Given this list of marker genes Gpha2, Reg3g, Sst (somatostatin), Prl3c1, Prl3d3, Gh, Retnlb, Prl8a1, Prl3d1, Kng2, Retnla, Nts, Fndc5, Iapp, Ostn, Nppa, Qrfp, Agrp, Sct (NCBI Gene Id 20287), Crhr2, Cga, Pdyn, Prl4a1, Pomc, Ecrg4, Ucn2, Inhbb, Metrn, Cort, Prl7a1, Lep, Crh, Bglap2, Nmb, Copa, Metrnl, Hamp2, Gfral, Gcg, Insl5, Adipoq, Rln3, Reg3b, Reg3a, Prl2b1, Cck, Prl2a1, Pthlh, Ucn, Galp, Avp, Vgf, Rln1, Adcyap1, Calcb, Prl5a1 (NCBI Gene Id 74232), Prl3d2, Prl6a1, Gnrh1, Enho, Edn2, Insl3 (insulin-like 3), Angptl8, Ttr, Gip, Prl2c5, Inhbe, Spx, Hcrt, Lhb, Vip, Inhba, Gphb5, Bmp10, Pmch, Prl7b1, a, Cartpt, Thpo, Gal, Npy, Bglap, Ucn3, Tg, Gdf15, Prl8a8, Igf1, Pth, Erfe, Edn3, Uts2b, Prl2c3, Apln, Uts2, Gast, Fbn1, Insl6, Adm2, Ins2, Inhbc, Prl3a1, Prl7a2, Fbn2, Pyy, Prl8a2, Ghrl, Trh, Apela, Hamp (hepcidin antimicrobial peptide), Ins1, Prl2c1, Prl8a9, Npff, C1qtnf12, Prl8a6, Adm, Kng1, Epo, Prl, Oxt, Retnlg, Prl7d1, Prl2c2, Stc1, Fshb (follicle stimulating hormone beta), Ppy, Grp, Ghrh, C1qtnf9, Prlh, Stc2, Nppb (natriuretic peptide type B), Nppc, Tshb, Prl3b1, Ccn3, Edn1, Igf2, Agt, 3110082I17Rik, Retn, Inha, Prl7c1, here is a description of the gene set: studied in species Mus musculus The action characteristic of a hormone, any substance formed in very small amounts in one specialized organ or group of cells and carried (sometimes in the bloodstream) to another organ or group of cells in the same organism, upon which it has a specific regulatory action. The term was originally applied to agents with a stimulatory physiological action in vertebrate animals (as opposed to a chalone, which has a depressant action). Usage is now extended to regulatory compounds in lower animals and plants, and to synthetic substances having comparable effects; all bind receptors and trigger some biological process. Mouse Gene Set: GOMF_HORMONE_ACTIVITY